The following is a description of a gene set: The initial translation products of SUMO1, SUMO2, and SUMO3 are precursors that have extra amino acid residues at the C-terminus. SUMO1 has 4 extra residues, SUMO2 has 2 extra residues, and SUMO3 has 11 extra residues. Proteolytic cleavage by SUMO peptidases (SENPs) removes the propeptide and leaves diglycine residues at the C-terminus. Each SENP has distinct preferences for certain SUMOs. SENP1 has highest activity on SUMO1; SENP2 and SENP5 have highest activity on SUMO2. SENP1 and SENP2 are predominantly nucleoplasmic and SENP5 is predominantly nucleolar (Di Bacco et al. 2006, Gong and Yeh 2006), therefore the processing reactions are believed to occur in the nucleus. The processed SUMO is then activated by formation of a thioester bond with a cysteine residue of an E1 enzyme, UBA2 (SAE2) in a complex with SAE1. SUMO is then transferred from the E1 enzyme to an E2 enzyme, UBC9 (UBE2I). species: Homo sapiens Reactome Pathway: Processing and activation of SUMO part of: SUMOylation, and this is the list of marker genes: SENP5, SAE1, SUMO2, RWDD3, UBA2, SUMO3, UBE2I, SUMO1, SENP1, SENP2